The following is a description of a gene set: from publication Kaizer EC, Glaser CL, Chaussabel D, Banchereau J, Pascual V, White PC (PMID 17595242) Genes up-regulated in comparison of peripheral blood mononuclear cells (PBMC) from patients with type 1 diabetes at the time of the diagnosis versus those at 1 month later. Objective: We hypothesized that type 1 diabetes (T1D) is accompanied by changes in gene expression in peripheral blood mononuclear cells (PBMCs) due to dysregulation of adaptive and innate immunity, counterregulatory responses to immune dysregulation, insulin deficiency and hyperglycemia. Research Design and Methods: Microarray analysis was performed on PBMCs from 43 patients with newly diagnosed T1D, 12 patients with newly diagnosed type 2 diabetes (T2D) and 24 healthy controls. One and four month follow-up samples were obtained from 20 of the T1D patients. Results: Microarray analysis identified genes differing in expression between newlydiagnosed T1D patients and controls at a false discovery rate of 0.05. Changes in expression of interleukin-1β (IL1B), early growth response gene 3 (EGR3), and prostaglandin-endoperoxide synthase 2 (PTGS2) resolved within four months of insulin therapy and were also observed in T2D suggesting that they resulted from hyperglycemia. With use of a knowledge base, 81/genes could be placed within a network of interrelated genes with predicted functions including apoptosis and cell proliferation. IL1B and the MYC oncogene were the most highly-connected genes in the network. IL1B was highly overexpressed in both T1D and T2D, whereas MYC was dysregulated only in T1D. Conclusion: T1D and T2D likely share a final common pathway for beta cell dysfunction that includes secretion of interleukin-1β and prostaglandins by immune effector cells, exacerbating existing beta cell dysfunction, and causing further hyperglycemia. The results identify several targets for disease-modifying therapy of diabetes and potential biomarkers for monitoring treatment efficacy. species: Homo sapiens Human Gene Set: GSE9006_TYPE_1_DIABETES_AT_DX_VS_1MONTH_POST_DX_PBMC_UP, and this is the list of marker genes: DUSP10, NCAPH2, ARF6, ECSIT, KIF2C, NCL, AHCY, NFYA, PRPF6, TSC22D3, SRSF9, GLOD4, MFN2 (mitofusin 2), SH3GLB2, FPR2, GSN, SLC6A6, ADAM10, BGLAP, HSP90B1, WDR46, TUBA4B, MRPL12, NRAS, HNRNPK, EGLN1, RASA3 (NCBI Gene Id 22821), ATP2A2, RBM42, KDELR2, CDCA4, CDT1, ACO2, HSPA5, PABPC4, STT3A, ACTR2, MARCKSL1, SIDT1, RCL1, MARCKS, ARL6IP1, JUNB, SART1, HMGB2, PDK4, KLHL2, IER3, PPIB, PRKDC, PIM1, CXCR4, UQCRC1, ODF2, ICAM3, ABCF1, ARPC4, TRAF3IP1, GALNT2, TMEM160, RRP12, ZFP36L1, BLK, FCAR, AMBRA1, KLF2, RTN3, PTBP1, CYBB, DUSP1, OSTF1, RAB8A, HNRNPR, PPIF, BMPR2, PDIA4, CYP51A1, HNRNPA1, CORO1C, ELMO1, P4HB, MAP4K4, GRAMD4, NAPG, ANP32A, CTSD, NSD1, TRIM58, GLUL, SVIL (supervillin), FARSA, RBM3, REX1BD, SLC25A20, FDXR, STX11, INTS3, SAFB2, PDIA3 (protein disulfide isomerase family A member 3), TMCO3, SAFB, PHF21A, YWHAZ, DNAJA2, MAFB, PTX3, FLI1, RBBP4, TBL3, PTBP3 (NCBI Gene Id 9991), HSPA9, RAB1B, EHD4, MAP3K8, GOLPH3, THOC6, ARAF, COPS7B, ZDHHC11, GPAA1, PAK2, EWSR1, DNAJC17, HNRNPA3, SOCS3, GSR, MAPRE1, GLUD2, POTEKP (NCBI Gene Id 90558), CDC37, PSPN, PRCC, ALDOA, RPN1, IFIT3, XAB2, TESK2, DGCR2, DDIT4, THBD, AAMP, PFN1, CLXN, LSM12, BSG (basigin (Ok blood group)), FKBP5, EREG, GPI, BTG1, FZR1, NFE2L2, AMDHD2, WDR18, COPG1, HBEGF, UBE2S, TPD52L2, BRMS1 (BRMS1 transcriptional repressor and anoikis regulator), AGPAT3, ATP8B2, TMEM259, SNRNP40, CCL2, IGKC, NDUFV1, GPR132, CDK2, PUF60, YBX3, PPP4R3A, SLC39A7, PPP4C, TSPAN14, HYOU1, SMU1, SEC31A, GLUD1, KIF4A, TMOD3, BANF1, ABCF3, SOCS1, ATP5F1D, CCDC22 (coiled-coil domain containing 22), NT5DC2, ILF2, ACTG1, RABAC1, CHFR (NCBI Gene Id 56732), PSMC3, HNRNPU, MSL2, HLX, CYBA, AGPS, HERPUD1, DAZAP2 (DAZ associated protein 2), CDK9, GBA1LP, DDX3X